The following is a description of a gene set: Human Gene Set: REACTOME_METABOLISM_OF_VITAMINS_AND_COFACTORS Metabolism of vitamins and cofactors species: Homo sapiens, and this is the list of marker genes: STARD7, APOC3 (NCBI Gene Id 440838), CYB5A, IDH1, NMRK2, LDLRAP1, MTR, ENPP1, AKR1C1, SDC4, CD38, SLC46A1, NAXE, SLC19A1, NMNAT2, SHMT2, CLPS, CTRB2, MCCC2, ALDH1L2, PCCB, PARP8, AGRN, MOCOS, SLC2A1, PTS, GPC3, MMACHC, MOCS2, MTHFR, UBIAD1, FOLR2, CTRB1, MOCS3, NADK, THTPA (thiamine triphosphatase), COQ9, GSTO1, ENPP3, NAPRT, ABCC1, BTD, PLB1, GCHFR, ACO1, CYB5R3, VKORC1 (vitamin K epoxide reductase complex subunit 1), PARP16, NAMPT, SDC1, LRP8, MMAB, HPDL, PARP6, SLC5A8, LDLR, PPCDC, APOC2, PANK1, COQ3, NUDT8, PARP10, GPC4, ALDH1L1, VNN2, FPGS (NCBI Gene Id 2356, folylpolyglutamate synthase), LPL, PANK3, AKR1B10, PPCS (NCBI Gene Id 79717), GPIHBP1, NMRK1, GPC1, NT5E, RFK, SLC52A1, PANK4, CBLIF, SLC19A3, RBP1, AKR1C3, BCO1, NADSYN1, SLC25A19, NOS3, SHMT1, SLC52A3, SLC23A1, SDC2, MTRR, ENPP2, LMBRD1, ACACB, NMNAT3, HSPG2, NUDT12, CUBN, BST1, VKORC1L1, SDC3, COQ6, MTHFD1L, MCCC1, SLC2A3, COQ4, GCH1, ACP5, GPC2, APOM, APOB, GSTO2 (NCBI Gene Id 119391), DHFR, SLC23A2, LRAT, COQ7, COASY, MTHFS, BCO2, COQ8A, LRP12, PDXK (NCBI Gene Id 8566), SLC5A6, PARP9, LRP2, PCCA, FLAD1, PNLIP, AKR1C4, GPHN, LRP1, NMNAT1, AMN, PARP4, DCAKD, TTPA, NADK2, COQ5, MTHFD1, MMADHC, SPR, PRSS3, CD320, TCN1, SLC22A13, SLC52A2, CALM1 (NCBI Gene Id 801), FASN, NNMT, QPRT, SLC25A16, SLC25A32, AKT1, RBP2, APOA4, RNLS, APOE, HSP90AA1 (heat shock protein 90 alpha family class A member 1), MMAA, VNN1, LRP10, ACACA, AASDHPPT, APOA2, MTHFD2L, PRKG2, SLC19A2, PNPO, TTR, SLC25A51, GPC5, HLCS, PDZD11, NAXD, RETSAT, ABCD4, SLC25A42, GPC6, PC, RDH11, PANK2, NFS1, PARP14, MMUT, MOCS1, PRSS1, MTHFD2, AOX1, DHFR2, COQ8B, PDSS2, TCN2, PDSS1, COQ2, TPK1, RBP4, APOA1